Given this list of marker genes AMDHD1 (amidohydrolase domain containing 1), HAL, UROC1, HDC, CARNS1, HNMT, CARNMT1, FTCD, here is a description of the gene set: Human Gene Set: REACTOME_HISTIDINE_CATABOLISM studied in species Homo sapiens Histidine catabolism